Given this list of marker genes SEMA3F, NRP1, NRP2, PLXNA3, PLXNA4, MYCBP2, SEMA3A, here is a description of the gene set: species: Homo sapiens Human Gene Set: GOBP_BRANCHIOMOTOR_NEURON_AXON_GUIDANCE The process in which a branchiomotor neuron growth cone is directed to a specific target site. Branchiomotor neurons are located in the hindbrain and innervate branchial arch-derived muscles that control jaw movements, facial expression, the larynx, and the pharynx.